The following is a description of a gene set: from publication Griffith AV, Fallahi M, Nakase H, Gosink M, Young B, Petrie HT (PMID 20064453) Genes up-regulated in thymus perimedullary cortical region versus the whole cortex. studied in species Homo sapiens Human Gene Set: GSE18281_PERIMEDULLARY_CORTICAL_REGION_VS_WHOLE_CORTEX_THYMUS_UP Interaction of hematopoietic progenitors with the thymic stromal microenvironment induces them to proliferate, adopt the T cell fate, and asymmetrically diverge into multiple T lineages. Progenitors at various developmental stages are stratified among different regions of the thymus, implying that the corresponding microenvironments differ from one another, and provide unique sets of signals to progenitors migrating between them. The nature of these differences remains undefined. Here we use novel physical and computational approaches to characterize these stromal subregions, distinguishing gene expression in microdissected tissues from that of their lymphoid constituents. Using this approach, we comprehensively map gene expression in functionally distinct stromal microenvironments, and identify clusters of genes that define each region. Quite unexpectedly, we find that the central cortex lacks distinctive features of its own, and instead appears to function by sequestering unique microenvironments found at the cortical extremities, and modulating the relative proximity of progenitors moving between them., and this is the list of marker genes: CCNO, TASOR, CPSF1, SRSF9, DDX27, EPHA7, CFP, KRT19, RXRA, ESPL1, SLITRK5, ARHGEF28, GLI3, THY1, MAB21L4, IFNA10, KRT4, PHACTR4, EPHA4, TYMS, CARM1, JUP, GABRP (gamma-aminobutyric acid type A receptor subunit pi), LIMK2, SLC34A2, NOTCH1, HES1, IRF5, CTDSPL, MYH1, R3HCC1L, IRF9, LYPLA2P1, BAP1, INHBB, TRPC4AP, GPR3, B3GALT5, GNA11, CLCN7, TAP1, KLK1, NKX2-8, NHERF1, SORBS3, ABCF1, INTS1, IPO5, SLC35D2, TSC2 (TSC complex subunit 2), MADCAM1, SPATS2L, GRINA, SMYD5, ZFHX3 (zinc finger homeobox 3), ADCY10, MED16, CHFR, ZNF500, TRMT2A, OR11A1, DNMT3B, TSPAN14, POLR2A, GEMIN4 (gem nuclear organelle associated protein 4), SPTBN2, CNKSR1, TLN1 (NCBI Gene Id 7094), PLXDC1 (plexin domain containing 1), KRT14, CPLANE2, NSD1, VSIG4, RITA1, PIMREG, KDM1A, IL13RA1, RC3H2, NUSAP1, PML, PUM2, CADM1 (cell adhesion molecule 1), CDC45, CHD8, EPN3, TCF7L1, FOXN3, EHMT2, ADGRG1, E2F2, CAPN5, BTG2, PNKP, PRKCD, PKN2, FAM222B, CEP55, CCDC51, PTMA (prothymosin alpha), ZNF142, INTS3, GIMAP4, PTCH2, UBAP2L, BCL9, NCOA1, TMEM109, BPTF (bromodomain PHD finger transcription factor), RIPK4, ZYX, CSK, IDUA, IRF1, MRPS27, MYCL, SSBP3, PSEN1, OIP5, AAR2, DEDD, NDC80, COL7A1, RUSC1, KHDRBS2, TBL1XR1, RALGDS, APOBEC2, CAMK1D, ARPC4, UPF1, PRKAB1, MCAM, HSPB1, CELSR1, HLA-C (major histocompatibility complex, class I, C), SLCO3A1, MYD88, CBX5, KLHL21, VCL, TP53AIP1, ITGB4, PELP1, ZNF609, FCGR2A, FUT6, DTL, PLXNB2, COCH, LRRC14, UBA1, PBK, ST6GALNAC2, MEPE, ASB9, PHLDA3, B3GNT3, VPS37B, GNPDA1, CENPE, MEN1, ERC1, KRT33A, DAPK2, ARRB2, PRKCZ, DRG2, CDO1, CIAO3, PPP2R2B, FBXO41, PTDSS1, LUZP2, CENPU, ADH1B (alcohol dehydrogenase 1B (class I), beta polypeptide), MIA3, MCM2 (NCBI Gene Id 94687), SOX13, PIAS3, SAE1, POGK, CDKN3 (NCBI Gene Id 1033), ANAPC2, CUEDC1, CILP, GNAT3, CYTL1, APLP2, SECTM1, IMPDH2, ERAL1, DCTN1, ANPEP, SPINK5, CPT1A, ERBB2, EPS8L2, KIF22, COG2, DEPTOR